Given this list of marker genes Hif1a, Add1, Cat, Ambp, Ldb1, Alas1, Axin1, Inha, Klf4, Lyn, Alas2, Hpx, Fech, Epo, Snx3, Epb42, Abcb10, Slc6a9 (NCBI Gene Id 14664), Tet2, Slc25a37, Inhba, Eif2ak1, here is a description of the gene set: Mouse Gene Set: GOBP_HEMOGLOBIN_METABOLIC_PROCESS The chemical reactions and pathways involving hemoglobin, including its uptake and utilization. species: Mus musculus